Given this list of marker genes MASP1, PHACTR4, FBXL20, RBMS2, FUS (NCBI Gene Id 406232), LHPP, TMEM239, EBAG9, OSBPL1A, DAB2IP (NCBI Gene Id 84635), NOL9, GDI1, RPL15, ZNF286B, TRAF3IP2, CDK8, SUSD5, SYNGR1, PACS1, PRND, CBX5, MTCL2, ANKS4B, ZFHX2, COL11A2, MTFMT (mitochondrial methionyl-tRNA formyltransferase), NOVA2, CDH1, ERBB3, EEF2K, IKZF3, DCTN5, RRP15, ARGFX, DDX6, MUCL3 (NCBI Gene Id 53370), CYP2B6, HRH2, CCL28 (NCBI Gene Id 56477), ACADSB, DMRT1, DYDC2, CASTOR2, HOOK3, TIAM1-AS1, ZNF793, SYP (NCBI Gene Id 6855), MDM4, GLS, PYCR3, FOXK1, BMAL2, PSMB2, CSF3R, FAM72A, ZNF490, GFRA4, DTX4, APOL6, DEPDC5, ATXN1, MIP, RHOJ, ZNF544, TMEM265, SCAI, FOXP4, EOGT, ZNF674, GAB2, FAM72B, DNAJC8, PRICKLE3, PARP9, PI3, APELA, GNAT1, ACKR2, CALCR, SHISA7, HUNK, NID1, ARID2, LRRC51, EFCAB2, SCGN, SV2C, CASP10, IGF2BP1, ITLN1 (NCBI Gene Id 55600), SH3BP2 (NCBI Gene Id 91018), MS4A10, CCDC28A-AS1, POLR2D, KCNIP1, CYP1A2, RAB21, GLG1, SLC6A11, SULT1E1, CYP20A1, CEBPZOS, ARNT2, MTX3, YWHAQ, ORAI2, TMTC1, ATP1B4, APOBEC3F, PNMA2 (NCBI Gene Id 11310), VPS13B, GFAP, CPSF7, ESYT1, VIRMA, ODAPH, STX5, MAVS, GPR83, MAPK13, SP8, SBSPON, CDADC1, GFOD2, PDE7A, ZNF432, TCTN2, SLC2A4, CHTF8, GNL3L, RALB, ZNF554, UPK2, LYZL1, CTSW, NSL1, CGNL1, CD164, CORO2B, MRPS2, FBXL18, RIMS3, ZDHHC15, MS4A1, PLEKHA5, PPP1R11, GNPNAT1 (glucosamine-phosphate N-acetyltransferase 1), PAPOLG, TMEM63C, MYO10 (myosin X), LYZL2, ZNF814, SETD7 (SET domain containing 7, histone lysine methyltransferase), ASPG, GCFC2, NCEH1, PYGO1, ELK1, ATP7B, NDST1, RBM19, TMEM132E, ZNF655, RAD51B, VPS25, SHOX, CTDSPL (CTD small phosphatase like), NMNAT2, SHISA6, MARK4, PLCXD1, FIBCD1, RRP7A, COL27A1, SYBU, PIGK, SAMD4A, IRGQ (NCBI Gene Id 126298), here is a description of the gene set: from publication Chen Y, Wang X (PMID 31504780) Human Gene Set: MIR30B_3P species: Homo sapiens Genes predicted to be targets of miRBase v22 microRNA hsa-miR-30b-3p in miRDB v6.0 with MirTarget v4 prediction scores > 80 (high confidence targets).